The following is a description of a gene set: The lipid bilayer surrounding the platelet alpha granule. species: Homo sapiens Human Gene Set: GOCC_PLATELET_ALPHA_GRANULE_MEMBRANE, and this is the list of marker genes: SYTL4, SNCA, LHFPL2, SELP, ITGB3, ITGA2B, PHACTR2, CYB5R1, TMX3 (thioredoxin related transmembrane protein 3), PCDH7, CD109, SPARC, LY6G6F, CD36, APLP2, CD9, PECAM1